Given this list of marker genes SLC22A3 (NCBI Gene Id 6581), UBE3A, DCN, PHLDA2, PPP1R9A, SGCE, ART5, IGF2, DLK1, TSPAN32, CDKN1C, SFMBT2, CALCR, DDC, PEG3, AIRN, H19, NAP1L5, PON2, MCTS2, CD81, SNRPN, ATP10A, SNURF, MAGEL2, QPCT, GATM, GRB10, IGF2R, MEST, COMMD1, CNTN3, RASGRF1, FRAT1, PEG10, ASB4, SCIN, KLRB1, CMAHP, MEG3, OSBPL5, KCNQ1, PON3, WT1, NDN, ASCL2, DHCR7, COPG2, APOC2, SLC22A2, INS, MST1R, TSSC4, TH, DRD1, SLC38A4, HTR2A, RB1, NNAT, SLC22A18, MKRN3, GNAS, FBXO40, IMPACT, NAP1L4, PLAGL1, here is a description of the gene set: Human Gene Set: BRIDEAU_IMPRINTED_GENES studied in species Mus musculus List of genomically imprinted genes. Approximately 100 mouse genes undergo genomic imprinting, whereby one of the two parental alleles is epigenetically silenced. Imprinted genes influence processes including development, X chromosome inactivation, obesity, schizophrenia, and diabetes, motivating the identification of all imprinted loci. Local sequence features have been used to predict candidate imprinted genes, but rigorous testing using reciprocal crosses validated only three, one of which resided in previously identified imprinting clusters. Here we show that specific epigenetic features in mouse cells correlate with imprinting status in mice, and we identify hundreds of additional genes predicted to be imprinted in the mouse. We used a multitiered approach to validate imprinted expression, including use of a custom single nucleotide polymorphism array and traditional molecular methods. Of 65 candidates subjected to molecular assays for allele-specific expression, we found 10 novel imprinted genes that were maternally expressed in the placenta. from publication Brideau CM, Eilertson KE, Hagarman JA, Bustamante CD, Soloway PD (PMID 20421412)